Given this list of marker genes Igfbp1, Bmper, Smoc2, Mfap4, Fbln7, Cthrc1, Mfap3, Col4a5, Rspo4, Hapln2, Lgi4, Col17a1, Tnr, Col28a1, Sparc, Comp, Pcolce2, Spock3, Lgi3, Slit1, Ntng2, Ints6l, Tnc, Fndc7, Slit2, Fbln1, Lamc3, Pcolce, Spp1, Igfbp7, Egflam, Vwa5a, Epyc, Vcan, Gas6, Smoc1, Col4a3, Vwce, Bcan, Ccn2, Ccn1, Matn2, Impg1, Tnfaip6, Zp2, Vit (NCBI Gene Id 78474), Thsd4, AW551984, Col4a1, Rspo2, Tsku, Tinag, Igfbp4, Sspo, Fgb (NCBI Gene Id 67908), Lamb3, Nid1, Prg4, Mfap2, Vwf, Otogl, Hmcn2, Lamc2, Col16a1, Ltbp2, Ndnf, Bgn, Fgl2, Srpx (NCBI Gene Id 53912), Igfbp3, Bglap2, Zp3r, Col9a2, Bsph1, Lamb1, Crim1, Amelx, Col15a1, Creld2, Dcn, Spon2, Zpld1, Abi3bp, Ccn6, Col27a1, Thbs3, Tgfbi, Ltbp1, Ntn4, Col5a1, Impg2, Lama3, Spock1, Tectb, Vwa5b2, Vwa5b1, Fbln2, Emid1, Nell1, Col8a1, Col9a3, Hmcn1, Fgg, Col24a1, Zp3, Ecm2, Postn, Cdcp2, Ccn3, Lum, Col26a1, Esm1, Lama4, Mfap5, Col25a1, Col11a2, Tspear, Zp1, Cilp, Matn1, Mfap1a, Col6a5, Dmp1, Agrn, Vtn, Hspg2, Col5a2, Ntng1, Fndc8, Dmbt1, Ibsp, Lamc1, Spon1, Ints14, Col12a1, Tecta, Chadl, Podnl1, Col10a1, Col1a1, Ntn3, Hapln1 (hyaluronan and proteoglycan link protein 1), Col8a2, Ltbp3, Vwa1, Aebp1, Col13a1, Igfals, Prg3, Thbs4, Mfge8, Spock2, Otog, Crispld1, Col11a1, Col6a4, Slit3, Papln, Col6a3, Thbs2, Emilin2, Bglap3, Matn4, Ambn, Vwa7, Srgn, Sparcl1, Podn, Col6a1, Lamb2, Svep1, Lrg1, Fga, Mepe, Igfbpl1, Gldn, Mmrn2, Omd, Cilp2, Optc, Col20a1, Fmod, Crispld2, Nyx, Efemp2 (epidermal growth factor-containing fibulin-like extracellular matrix protein 2), Rspo3, Reln, Eln, Edil3, Ntn1, Ltbp4, Npnt, Efemp1, Tnn, Col6a6, Lama5, Acan, Vwa3b, Pxdn, Ccn4, Tinagl1, Mfap1b, Col18a1, Prelp, Hapln3, Fgl1, Emilin1, Rspo1, Hapln4, Fras1, Igsf10, Chad, Ncan, Igfbp2, Nid2, Dpt, Lama1, Fbn2, Lgi1, Otol1, Col5a3, Col7a1, Oit3, Igfbp5, Dspp, Col6a2, Col19a1, Slamf6, Adipoq (adiponectin, C1Q and collagen domain containing), Kcp, Mgp, Lgi2, Colq, Col9a1, Prg2, Ccn5, Lama2, Vwa3a, Sbspon, Fn1, Matn3, Nell2, Tnxb, Col22a1, Col23a1, Coch, Emilin3, Bsph2, Egfem1, Aspn, Fndc1, Sned1, Col1a2, Ogn, Creld1, Igfbp6, Vwde, Ntn5, Col2a1, Nepn (nephrocan), Kera, Ecm1 (NCBI Gene Id 99700), Srpx2, Vwa2, Fbln5, Thbs1, Col4a4, Col4a6, Fbn1 (fibrillin 1), Col14a1 (collagen, type XIV, alpha 1), Cdcp3, Col4a2, Mmrn1, Col3a1, here is a description of the gene set: Ensemble of genes encoding core extracellular matrix including ECM glycoproteins, collagens and proteoglycans One hallmark of ECM proteins is their domain-based structure. Exploiting this characteristic, we established a list of diagnostic InterPro domains commonly found in ECM proteins. We know that some of the domains used to select positively for ECM proteins are also found in transmembrane receptors and proteins involved in cell adhesion (growth factor receptors, integrins, etc) that do not belong to the ECM. These families of proteins also display a subset of specific domains and transmembrane domains incompatible with definition as species: Mus musculus from publication Naba A, Clauser KR, Hoersch S, Liu H, Carr SA, Hynes RO (PMID 22159717) Mouse Gene Set: NABA_CORE_MATRISOME